The following is a description of a gene set: species: Homo sapiens Human Gene Set: GOBP_HORMONE_CATABOLIC_PROCESS The chemical reactions and pathways resulting in the breakdown of any hormone, naturally occurring substances secreted by specialized cells that affects the metabolism or behavior of other cells possessing functional receptors for the hormone., and this is the list of marker genes: DIO3, ACE, DIO2, ECE1, CPA4, IDE, MME, SRD5A1, SULT1E1, CYP19A1, HSD17B6, HSD17B11, SPP1, DIO1